Given this list of marker genes Ap3m2, Calm3, Slc17a7, Aak1, Ap2a1, Ap2a2, Pacsin1, Ston1, Capn2, Mx2, Scamp5, Mff, Slc2a4, Fcho2, Necap1, Btbd8, Vamp4, Pip5k1c, Cltb, Syt11, Ophn1, Scrib, Bcl2l1, Arpc3, Kcnc3, Ctbp1, Snx9, Atp8a1, Ston2, Actb, Ap3b2, Snca, Rab27b (NCBI Gene Id 80718), Vamp2, Nlgn1, Syt7, Ap3s1 (adaptor-related protein complex 3, sigma 1 subunit), Prkn (parkin RBR E3 ubiquitin protein ligase), Ap2m1, Synj2, Sh3gl1, Tor1a, Dnajc6, Dnm3, Grn, Ppp3cb, Actg1, Arfgap3, Ap2b1 (adaptor-related protein complex 2, beta 1 subunit), Cltc, Lrrk2, Dennd1a, Sncg, Itsn1, Sh3gl2, Picalm, Canx, Pik3c3, Ppp3cc, Abca13, Sncb, Nlgn3, Sgip1, Ap3d1, Dnm1l, Dnm2, Cd24a, Amph, Rac1, Dgkq, Park7, Rock1, Synj1, Calm2, Btbd9, Dnm1, Bin1, Arf6, Cxadr, Bltp1, Calm1, Ap2s1, Snap91, Cdk5, Eps15l1, Tbc1d24, Ap3s2, Itsn2, Stx1a, Diaph1, here is a description of the gene set: studied in species Mus musculus Mouse Gene Set: GOBP_PRESYNAPTIC_ENDOCYTOSIS A vesicle-mediated transport process in which the presynapse take up external materials or membrane constituents by the invagination of a small region of the plasma membrane to form a new membrane-bounded vesicle.